Given this list of marker genes Zc3h8, Stag1, Alx1, Cdc5lrt5, Ncam2, Ascc1, Tert, Ddx1, Dnaaf1, N4bp1, F8a, U2af1l4, Hspb7, Cenpc1, Bnip3l (BCL2/adenovirus E1B interacting protein 3-like), Dach1, Klhdc2, Rsrc1, Yme1l1, Fev, Erbin, Sh3bgrl3, Ell, Srsf9, Ints13, Nt5c3, Snrpd3 (NCBI Gene Id 78379), Rere, Plagl1, Pla2g6, Morf4l1, Magoh, Snw1, Cstf2, Ngrn, Hectd1, Zfp982, Zfp174, Stk19, Ube2o, Pcbp1, Knl1, Ppp4r3a, Dazap2, Suz12, H1f0, Ewsr1, Lars1, Sgo1, Crebrf, Sry, Tcf7, Crebbp, Serpinb13, Mcrs1, Nphp4, Tbxa2r, Cbx6, Unc45a, Hnrnpa2b1, Nek6, Spn, Rbm10, Prdm5, Rorc, U2af1, Msl1, Bnip3l-ps, Patl1 (NCBI Gene Id 225929), E4f1, Creb3, Nop10, Myc, Bpnt2, Papolg, Oip5, Aff2, H2ax, Chfr, Flywch1, Ppwd1, Nrde2, Cdc5lrt6, Rdm1, Nup98, Eaf2, Tmem179b, Srp54a, Mki67, Nbr1, Arrb1, Ncbp3, Dusp11, Hp1bp3 (NCBI Gene Id 15441), Cactin, Gemin4, Sel1l2, Tcim, Spag5, Cbx4, Cd2bp2, Cep89, Abraxas1, Slu7, Pir, Polr2d, Hdac4, Ifi211, Rbbp6, Rb1, Brd2, Gata4, Inppl1, Stap1, Rpn2, Chd5, Srsf10, Ercc6, Hcfc2, Klhl20, Dync2i2, Zfp758, Mbd4, Magea8, Nampt, Ccnl2, Plrg1, Usp7, Pole2, Sart3, Afdn, Dyrk1a, Nelfe, Eif3e, Sbf1, Sarnp, Ppp1r8, Pnisr, Senp3, Tspan15, Cdc5lrt10, Exo1, Gemin5, Ppie, Nup43, Stk10, Snrnp40, Npm1, Hoxb7, Sqstm1, Stk35, Gtf2b, Gpr143, Pomp, Casp8ap2, Dgkb, Scrt1, Sfmbt2, Hinfp, Rexo1, Cdc5lrt1, Cxxc1, Adgrd1, Trip4, Chek2, Morc3, Snrpa1, Heatr5b, Aff3, Ptprj, Setd1a, Hif3a (hypoxia inducible factor 3, alpha subunit), Cwc22rt1, Rbm39, Stk4, Tinf2, Rpa1, Faap20, Fbxl3, Fibp, Zfp202, Syf2, Terf1, Toe1, Zic2, Mdc1, Prdm8, Trp53bp1, Topors, Ndufs3, Sf1, Carmil1, Thoc3, Fbxl4, Satb1, Wbp11, Thrb, Gemin6-ps, Pml, Obscn, Arhgap18, Aipl1, Mocs2, Arglu1, Lpxn, Rnu6, Zwint, Mns1, Myct1, Srsf4, Rfxap, Klf11, Dgkq, Srrm2, Hmg20b, Ncoa2, Habp4, Malat1, Phax, Polk, Bhlhe40, Prpf8, Corin, Fancl, Ik, Amer1, Rbm15b, Pin1, Gatad2b, Ctr9, Atmin, Surf2, Bcl11a, Sap130, Ddx39b, Polr3g (polymerase (RNA) III (DNA directed) polypeptide G), Sprtn, Ralbp1, Dtx1, Gadd45a, Sympk, Bcas2, Atpaf2, Setbp1, Gemin8, Srcap, Zfp473, Rbm4b, Arnt, Hoxa6, Ush1g, Rapgef5, Elf4, Zfp451, Fyttd1, Zmym2, Gemin7, Wtap, Csnk1a1, Mindy1, Lyrm4, Ddx46 (NCBI Gene Id 73645), Smu1, Thap1, Cwc22rt5, Ptprh, Fancg, Tenm1, Trim69, Gemin2, Ptk2, Taok1, Usp15, Thoc6, Sirt1, Nr4a2, Pip5k1a, Srek1, Taf5l, Ino80b, Foxf2, Hipk1, Hipk3, Incenp, Cops4, Blm, Slf2, Neat1, Prkn, Trp53inp2, Ylpm1, Pqbp1, Ring1, Fto, Lrch4, Tarbp2, Cdk12, Slc28a1 (solute carrier family 28 (sodium-coupled nucleoside transporter), member 1), Mapk14, Dsn1, Fancd2, Prpf4, Snapc5, Tfip11, Cbx5, Hipk2, Rnf6, Wt1, Hsf4, Parg, Tcf20, Eng, Fam76b, Rufy1, Ppp4r3b, Akap8l (A kinase anchor protein 8-like), Sptbn4, Srrt, Nfatc1, Adamts4 (NCBI Gene Id 240913), Zbtb20, Hnrnpm (heterogeneous nuclear ribonucleoprotein M), Eya1 (NCBI Gene Id 14048), Srsf2, Dhx15, Mau2 (NCBI Gene Id 97456), Scaf11, Marcks, Bmi1, Zfp677, Eftud2, Nr2c1, Uimc1, Angel2, Cby1, Kmt2e, Nr1h4, Bmp2k, Csnk2b, Pabpn1, Tcf12, Tpp2, Nr0b1, Sgo2b, Rnf32, Cenpo, Gli2, Mbd1, Myo1c, Sdcbp2 (NCBI Gene Id 228765), Apbb3, Clk2, Sugt1, Gli3, Cenpi, Cwc22rt6, Frg1, Ints7, Pabir1, Cwc22rt3, Ankrd2, Nufip2, Cacnb4, Arih1, Fam76a, Pou4f2, Magea2, Dcaf7 (NCBI Gene Id 97751), Rbm8a, Abitram, Rnf111, Srsf3 (serine and arginine-rich splicing factor 3), Aire, Tesk2, Ndufb1, Prkaa1, Lage3, Wbp4, Rnps1, Apex1, Smc4, Cdc40, Safb2, Eif4a3, Gon4l, Cmya5, Cnot7, Mecom, Ddx20 (NCBI Gene Id 53975), Otp, Pcnp, Smndc1, Raph1, Hira, Phf7, Sumo2, E2f7, Nxt1 (NTF2-related export protein 1), Prkaca, Hif1a, Kctd13, Noc3l, Epas1, Sgo2a, Terf2ip, Cdt1, Glis2, Magea5, Pnn, Ice1, Nfkbiz, Rchy1, Tnks (NCBI Gene Id 97475), Lsg1, Hsf1, Dgcr8, Gcat, Gnl3, Kif22, Atrx, Drg1, Scnm1, Myocd, Epor, Jade1, Nr4a1, Uhmk1, Dennd1b, Rnf2, Hikeshi, Helb, Tdg, Ehmt1, Smc6, Bola3, Slc34a1 (NCBI Gene Id 20505), Cdkn2a, Nhp2, Smurf2, Med7, Nono, Kif2a, Atr, Mtdh, Ino80, Treml1, Baz2a, Pdx1, Add1, Cdc5lrt7 (NCBI Gene Id 668205), Cwc25, Dhx9 (DExH-box helicase 9), Il15, Trp53, Ciita, Zbtb16, Ascc3, Top3a, Ccndbp1, Csf1, Bclaf1, Dhx8, Sf3a1, Akap17b, Ppig, Nrip1, Dhx36, Rbm15, Rbm8a2, Wrap53, Stk16, Ogg1, Srpk1, Gtf3c6, Fmr1, Fam193b, Rnf34, Timm50, Ect2, Xpo1, Dclre1b, Alkbh5, Atf4, Arl6ip4, Phc1, Vps72, Apbb1, Dkc1, Nhs, Zcchc12, Sp3, Tut1, Plekhh2, Rnf112, Tap2, Zfp957, Celf3, Gar1, Setd1b, Sap18b, Mknk2, Calcoco2, Lsm11, Adar, Yars1, Ppih, Ice2, Cdc34b, Bard1, Parp3, Msantd1, Gtf2h2, Rbm27, Coil, Rpa2, Pacsin2, Cdk9, Senp2, Ccnb3, Dzip1, Nr3c1, Rpgrip1l (Rpgrip1-like, NCBI Gene Id 73313), Cdkn1a, Nsl1, Hnrnpu (heterogeneous nuclear ribonucleoprotein U), Srsf7, Gfi1, Isg20, Dvl2, Atp8b1, Pdgfra, Hivep1, Ddx42, Ncor2, Ikzf4, Parp11, Ythdc1, Cygb, Cenpb, Sumo3, Snapc3, Npat, Hhex (hematopoietically expressed homeobox), Srp19 (NCBI Gene Id 66384), Hoxa4, Poli, Ppihl (peptidyl prolyl isomerase H like), Brca1, Zfp106, Alyref, Tollip, Hexim2, Ilrun, Foxc2, Eapp, Prpf40b, Prpf4b, Esrp1, Rpain, Sgk1 (NCBI Gene Id 20393), Atp6v0a1 (ATPase, H+ transporting, lysosomal V0 subunit A1), Chd3, Mapk9, Nmnat1, Garin3, Tardbp, Rbm11, Sf3a3, Snrpc (U1 small nuclear ribonucleoprotein C), Orc3, Pskh1, Ell3, Sfpq, Msra, Lpar4, Srsf5 (serine and arginine-rich splicing factor 5), Ap5z1, Pias4, Trim16, Snrnp70, Ehmt2, Elf2, Prkaa2, Psmb7, Hr, Cdk13, Luc7l2, Tmem237, Snrpb2, Wrn, Plcb1, Chtop, Nr1i2, Sp100, Atxn2l, Banp, Nsrp1, Sim2, Rbm4, Zbtb1, Cdc34, Virma, Srsf1, Il16, Prpf18, Zfp638, Scn1a, Srsf11, Rad54l2, Prcc, Zpr1, Cdc5l, Lsm10, Zfhx3, Parp1, Aff4, Hace1, Msx2, Clic3, Nelfa, Smc5, Ppp1r16b (NCBI Gene Id 277461), Srrm1, Pias3, Mettl3, Ranbp9, Uqcc2, Prpf19, Rbm25, Dgkz, Hbp1, Tab1, Epb41, Thoc2, S100pbp, Nme8, Mtor, Champ1, Kazn, Cop1, Psme4, Rtn1, Zfp830 (zinc finger protein 830), Palb2, Fas, Mamld1, Gtf2h4, Zfp217, Kif18b, Mapk7, Becn1, Bmal1, Ctcfl, Magea4, Babam1, Nolc1, Foxo4, Ddx17, Maml1, Cwc15, Cdc5lrt9, Mdm2, Ppp2r3c, Snurf, Lhpp, Atf7ip, Trim25, Atoh8, Adprs, Cib1, Trip12, Sap18, Nr1d1, Mlip, Pak2, Mre11a, Phf5a, Srsf8, Ppp1cc, Csnk2a1, Crnkl1, Zc3h14 (NCBI Gene Id 75553), Xrra1, Prpf6, Pias1, Telo2, Gemin6, Pcgf2, Ski, Thoc1, A230006K03Rik, Nxf1, Phpt1, Tgs1, Poldip3, Plag1, Eaf1, Rexo4, Brd1, Park7, Ak6, Nop58, Nudt21, Radx, Cep152, Wdfy3, Ivl, Trim27, Rreb1, Ddx5, Nudt9, Inava, Spop, Cbx2, Kat6a, Ppp1r10, Dapk3, Rmi2, Cenpt, Pasd1, Suds3, Eif4e, Dync2li1, Inca1, Mrpl36 (NCBI Gene Id 94066), Rp9, Pten, Scaper, Thap7, Sirt7, Grcc10, Cwc22, Rnf169, Pspc1, Uspl1, Ascc2, Sltm, Cdyl, Magea10, Dnajc11, Cdc25c, Nsmce2, Nsmce4a, Fbll1, Fam118b, Terf2, Cbll1, Prdm15, Prpf3, Ss18l1, Prpf31, Cwc22rt2, Vrk1, Fam107a, Ruvbl1, Tonsl, Epc1, Pkn2, Rnf4, Sf3b1, Nfatc4, Klf15, Magea3, Ckap4, Limk1, Nbn, Casc3, Agap3, Hspb6, Rgs10, Ubox5, Rbm19, Topbp1, Fli1, Cdc14a, Gm4275, Ahctf1, Fbl, Cbx1, Hmbox1, Tgfbr2 (NCBI Gene Id 76304), Grk5 (NCBI Gene Id 14773), Rgs14, Meox2 (NCBI Gene Id 17286), Xist, Miat, Yars2, Ddx39a, Srpk2 (serine/arginine-rich protein specific kinase 2), Cdc5lrt8, Cgas, U2af2, Srsf6, Crtc1, Smn1, Wac, Chrna3, Ube2i, Trim8, Itpkc, Rad51, Pou2f3, Esx1, Acaa2, Rad18, Bcl6, Tbc1d30, Max, Zbtb18, Abhd17a, Mrpl44, Hspa1a, Fastk, Hdac5, Prx, Rpl4, Rbm14, Mef2c, Ikbke, Sumo1, Zbtb4, Trp53inp1, Ncapg2, Cpsf6, Ndc80, Naa15, Ar, Eif4enif1, Smchd1, Snapc2, Ep400, Smad6, Lrrc28, Rtel1, Bnc2, Myh9, Sde2, Hspb3, Acd, Ptk6 (PTK6 protein tyrosine kinase 6), Maml3, Ciart, Simc1, Ifi204, Cwc22rt4, Skil, Parn, Tle2, Iqch, Zc3h18, Nfe2, Ppargc1a, Dock1, Eif2d, Mtrex, Ighmbp2, Ro60, Pcna, Sh3bp5, Acin1, Zcchc8, Ccnl1, Gpatch2, Rmi1, Hoxd3, Sf3a2, Api5, Ubash3a, Daxx, Basp1, Zc3h13, Retreg1, Zfp395, Hspa1b, Dbf4, Thoc7 (THO complex 7), Sugp2, Itgb1bp1, Trim41, Usp36, Pias2, Mcidas (NCBI Gene Id 632552), Luc7l3, Cdc5lrt4, Etaa1, Cry2, Dyrk3, Prpf40a, Tdp2, Ptpn23, Tkt, Hoxc10, Thrap3, Tcf7l2, Cdk2, Cwc22rt7, Rfwd3, Son (Son DNA binding protein), Zgrf1, Wwtr1, Sart1, Lmna, 4931406C07Rik, Tenm2, Abl1, Setx, Usp28, Aagab, Cir1, Atf3, Ubn1, Nuggc, Sf3b2, Gatad2a, Mapt, Rp2, here is a description of the gene set: Extra-nucleolar nuclear domains usually visualized by confocal microscopy and fluorescent antibodies to specific proteins. studied in species Mus musculus Mouse Gene Set: GOCC_NUCLEAR_BODY